Given this list of marker genes ECPAS, ANGEL2, PTAR1, FBXL20, MED16, ALPK1, PLEKHG2, MBTPS1, RNF157, RAMP1, ZMYND11, B3GALT1, IDS, GGA3, PSAP, RASGRF2 (NCBI Gene Id 89993), ATP11A, HLCS, SIK3, DNAJC27, RELT, TBC1D19, PELP1, ARMCX2, CCDC88A, MIPEP, FMNL1, OSBPL11, HABP4, CXXC1, SYDE2, TPCN1, PHF8, KCNF1, CLUAP1, CPNE4, KAT7, WDTC1, MIR202, IFT74, FAM76A, USP33, OTULIN, ATF6B, AGO1 (NCBI Gene Id 26523), CUL4A, TTBK2, DPP7, NNT, B3GALT2, TFDP2 (transcription factor Dp-2), GTF3C2, ATRNL1 (NCBI Gene Id 26033), YPEL5, DNMBP, KIAA0319L, THOC5, SYNJ1, VCL, NAPB, ANKS3, CLEC16A, ACBD4, R3HDM2, SHLD2, AKIRIN2, GOLGA3, PATJ, COL6A4P1, RNPEPL1, PI4KB, PFKP, UPF1, ERAL1, BLM, CEP135, SORL1, GBA2, DENND10, COG3, INPPL1, CREBL2, CTDSPL2, GCH1 (NCBI Gene Id 93984), POGZ, CBLB, DENND6A, DOCK8, IRAK1BP1, CTDSP1, DIDO1, TBC1D23, CSNK1G1, RAB3D, LYPLAL1, WDR73, UBR5, IFT52, CASC3, CD3E, IARS2, ATG4B, RBM4B, TTC17, SETD1B, GNB4, ST6GALNAC1, EIPR1 (EARP complex and GARP complex interacting protein 1), R3HDM1, MTMR2, RBM22, ATG12, MIR98, ADI1, ZNF106, MPP7, TNFAIP8L1, RPRD2, WDR83OS, NIPSNAP1, RYR2, AP1M1, CSK, WDR76, GRK4, VPS13C, RFX1, RETREG2, PRDM9, DDX5, USP32, HDDC3, ARHGEF7, UBE3C, BCL2L15, VAT1, BCOR, RPTOR, SUPT20H, WDR35, IFT140, SCAMP3, CDKL5, USP21, KCNA2, FNDC3A, ITPR2, NUDCD3, PPP6R1, AKAP11 (A-kinase anchoring protein 11), TNRC6A, MLXIP, RB1 (NCBI Gene Id 92728), KLHL42, IFT81, ZDHHC9, ALDH5A1, TAOK2, VPS8, NFYC, CRAT, RTN4, SORD, TDP1, PCMTD1, SF1, here is a description of the gene set: Human Gene Set: GSE10147_IL3_VS_IL3_AND_HIVP17_STIM_PDC_UP from publication Fiorentini S, Riboldi E, Facchetti F, Avolio M, Fabbri M, Tosti G, Becker PD, Guzman CA, Sozzani S, Caruso A (PMID 18310327) Genes up-regulated in plasmacytoid dendritic cells: IL3 versus IL3 and the HIV matrix protein p17. species: Homo sapiens We used microarrays to detail the global program of gene expression underlying the effect of p17 on human plasmacytoid dendritic cells and was compared to CpG profile.